The following is a description of a gene set: FOXO6, the least studied member of the FOXO family, directly stimulates transcription of PLXNA4 gene, encoding a co-factor for the semaphorin SEMA3A receptor. FOXO6-mediated regulation of PLXNA4 expression plays an important role in radial glia migration during cortical development.<br>FOXO-mediated up-regulation of genes involved in reduction of the oxidative stress burden is not specific to neurons, but plays an important role in neuronal survival and neurodegenerative diseases. FOXO3 and FOXO4, and possibly FOXO1, directly stimulate transcription of the SOD2 gene, encoding mitochondrial manganese-dependent superoxide dismutase, which converts superoxide to the less harmful hydrogen peroxide and oxygen. FOXO4 stimulates SOD2 gene transcription in collaboration with ATXN3, a protein involved in spinocerebellar ataxia type 3 (SCA3). FOXO3 and FOXO6, and possibly FOXO1, directly stimulate transcription of the CAT gene, encoding catalase, an enzyme that converts hydrogen peroxide to water and oxygen, thus protecting cells from the oxidative stress.<br>FOXO transcription factors regulate transcription of several genes whose protein products are secreted from hypothalamic neurons to control appetite and food intake: NPY gene, AGRP gene and POMC gene. At low insulin levels, characteristic of starvation, FOXO transcription factors bind to insulin responsive elements (IRES) in the regulatory regions of NPY, AGRP and POMC gene. FOXO1 directly stimulates transcription of the NPY gene, encoding neuropeptide-Y, and the AGRP gene, encoding Agouti-related protein, which both stimulate food intake. At the same time, FOXO1 directly represses transcription of the POMC gene, encoding melanocyte stimulating hormone alpha, which suppresses food intake. When, upon food intake, blood insulin levels rise, insulin-mediated activation of PI3K/AKT signaling inhibits FOXO transcriptional activity.<br>In liver cells, FOXO transcription factors regulate transcription of genes involved in gluconeogenesis: G6PC gene, encoding glucose-6-phosphatase and PCK1 gene, encoding phosphoenolpyruvate carboxykinase. Actions of G6PC and PCK1 enable steady glucose blood levels during fasting. FOXO1, FOXO3 and FOXO4 directly stimulate PCK1 gene transcription, while all four FOXOs, FOXO1, FOXO3, FOXO4 and FOXO6 directly stimulate G6PC gene transcription. FOXO-mediated induction of G6PC and PCK1 genes is negatively regulated by insulin-induced PI3K/AKT signaling.<br>FOXO1, FOXO3 and FOXO4 directly stimulate transcription of the IGFBP1 gene, encoding insulin growth factor binding protein 2, which increases sensitivity of cells to insulin.<br>FOXO1 and FOXO3 directly stimulate transcription of the ABCA6 (ATP-binding cassette sub-family A member 6) gene, encoding a putative transporter protein that is thought to be involved in lipid homeostasis. The GCK (glucokinase) gene is another gene involved in lipid homeostasis that is regulated by FOXOs. FOXO1, acting with the SIN3A:HDAC complex, directly represses the GCK gene transcription, thus repressing lipogenesis in the absence of insulin. The SREBF1 (SREBP1) gene, which encodes a transcriptional activator required for lipid homeostasis, is directly transcriptionally repressed by FOXO1. Transcription of the RETN gene, encoding resistin, an adipocyte specific hormone that suppresses insulin-mediated uptake of glucose by adipose cells, is directly stimulated by FOXO1.<br>Transcription of two genes encoding E3 ubiquitin ligases FBXO32 (Atrogin-1) and TRIM63 (MURF1), involved in degradation of muscle proteins and muscle wasting during starvation, is positively regulated by FOXO transcription factors. Reactome Pathway: FOXO-mediated transcription of oxidative stress, metabolic and neuronal genes studied in species Homo sapiens part of: FOXO-mediated transcription, and this is the list of marker genes: ABCA6, NPY, NR3C1, SOD2, SIN3A, FOXO3, ATXN3, SREBF1, FOXO6, AGRP, RETN, PPARGC1A, TRIM63, SMAD2, FOXO1, PLXNA4, FBXO32, SMAD3, CAT, SIRT3, POMC, INS, IGFBP1, FOXO4, GCK, PCK1, SMAD4, G6PC1, HDAC1, HDAC2